Given this list of marker genes LONP2, GNGT1, RGS7, FBXW9, GNA14, CSNK2A2, TUBB3, SPHK1, GNG3, AP3M1, TUBA4B, GNG4, PDCL, TP53, RGS6, PFDN5, USP11, GNG2, HDAC3, RGS9, DCAF7, GNB2, GNG11, CCT4, GNG5, FKBP9, CCT5, GNG7, TUBA1C, ARFGEF2, GNG8, CCT7, GNA11, KIF13A, XRN2, TUBAL3, TUBA1B, RGS11, TUBA4A, GNB3, PFDN6, CCNE2, TCP1, TUBA1A (tubulin alpha 1a), PFDN4, GNG10, FBXW4, GNB5, GNG12, FBXW10, TUBB2B, TUBB6 (NCBI Gene Id 84617), CCT2, ACTB, CCNE1, TUBA3C, TUBA3E, CCT6B, FBXO6, GNGT2, GNB1, FBXW7, NOP56, CCT8, TUBA3D, TUBA8, CCT6A, FBXW5, TUBB1, GBA1, GNB4, CSNK2B, FBXW2, TUBB4B, WRAP53, TUBB2A, GNAQ, VBP1, GAPDHS, GNG13, SKIC2, PFDN2, FBXL3, FBXO4, KIFC3, FBXL5, GNA15, TUBB4A, CCT3, STAT3, CSNK2A1, PFDN1, here is a description of the gene set: The eukaryotic chaperonin TCP-1 ring complex (TRiC/ CCT) plays an essential role in the folding of a subset of proteins prominent among which are the actins and tubulins. CCT/TRiC is an example of a type II chaperonin, defined (in contrast to type I) as functioning in the absence of a cochaperonin. TriC/CCT is a multisubunit toroidal complex that forms a cylinder containing two back-to-back stacked rings enclosing a cavity where substrate folding occurs in an ATP dependent process. CCT/TriC contains eight paralogous subunits that are conserved throughout eukaryotic organisms. CCT-mediated folding of non-native substrate protein involves capture through hydrophobic contacts with multiple chaperonin subunits followed by transfer of the protein into the central ring cavity where it folds. Although folding is initiated within this central cavity, only 5%-20% of proteins that are released have partitioned to the native state. The remaining portion is then recaptured by other chaperonin molecules. This cycling process may be repeated multiple times before a target protein partitions to the native state. In the cell, binding to CCT occurs via presentation of target protein bound to upstream chaperones. During translation, the emerging polypeptide chain may be transferred from the ribosome to CCT via the chaperone Prefoldin or the Hsp70 chaperone machinery. While the majority of CCT substrates ultimately partition to the native state as soluble, monomeric proteins, alpha and beta tubulin are unusual in that they require additional cofactors that are required to assemble the tubulin heterodimer. studied in species Homo sapiens part of: Protein folding Reactome Pathway: Chaperonin-mediated protein folding